The following is a description of a gene set: studied in species Homo sapiens Human Gene Set: REACTOME_RHOV_GTPASE_CYCLE RHOV GTPase cycle, and this is the list of marker genes: EPHA2, PARD6B (NCBI Gene Id 84612), NCK1, TXNL1, ARHGAP12, TPM3, ARHGEF7, NCK2 (NCBI Gene Id 8440), GIT2, CEP97, PAK2, DST (NCBI Gene Id 80105), TPM4, GIT1, PAK1, ZNF512B, DEPDC1B, PEAK1, CCP110, DLG5, WDR6, VANGL1, PIK3R1, SH3RF1, IQGAP1, MYO9A, SPTAN1, MAP3K11, PARD6A, CLTC, CDC42, WASL, PAK4, USP9X, SPTBN1, PAK6, RHOV